The following is a description of a gene set: The appearance of interleukin-5 due to biosynthesis or secretion following a cellular stimulus, resulting in an increase in its intracellular or extracellular levels. Human Gene Set: GOBP_INTERLEUKIN_5_PRODUCTION studied in species Homo sapiens, and this is the list of marker genes: PRKCZ, SCGB1A1, IL33, CRLF2, FOXP3, IL9, IL17RA, PDE4D, IL1RAP, RARA, TNFRSF21, IFNA2, IL17RB, TSLP, GATA3, IL5RA, IFNL1, LGALS9, EPX, LILRB4, IL1RL1, LEF1